The following is a description of a gene set: studied in species Homo sapiens Genes containing one or more binding sites for (ZNF138) in their promoter regions (TSS -1000,+100 bp) as identified by GTRD version 20.06 ChIP-seq harmonization. from publication Yevshin I, Sharipov R, Kolmykov S, Kondrakhin Y, Kolpakov F (PMID 30445619) Human Gene Set: ZNF138_TARGET_GENES, and this is the list of marker genes: OR1X5P, NOL6, TTC1 (tetratricopeptide repeat domain 1), RRN3P1, CWC25